Given this list of marker genes HOXA5, TNFRSF11A, ESR1, CCND1, ERBB4, PRLR, EGF, VEGFA, FOXF1, DDR1, AREG, TGFA, FOXB1, ID2, PHB2, AR, SOCS2, HIF1A, TNFSF11, TPH1, here is a description of the gene set: Human Gene Set: GOBP_MAMMARY_GLAND_ALVEOLUS_DEVELOPMENT The progression of the mammary gland alveolus over time, from its formation to its mature state. The mammary gland alveolus is a sac-like structure that is found in the mature gland. studied in species Homo sapiens